The following is a description of a gene set: Constipation for longer than three months with fewer than 3 bowel movements per week, straining, lumpy or hard stools, and a sensation of anorectal obstruction or incomplete defecation. studied in species Homo sapiens Chronic constipation Human Gene Set: HP_CHRONIC_CONSTIPATION, and this is the list of marker genes: SLC38A3, PWRN1, LMNB1, CREBBP, H4C5, TRIM8, ELN, MYH11, BICRA, MYO1H, FBXO28, DDOST, MLXIPL, ASH1L, EHMT1, IPO8, CAMK2B, COL1A1, DNAJC13, B2M, PHOX2B, ODC1, EP300, ADNP (NCBI Gene Id 256440), SMO, SH2B1, UBE2A, HERC2, TFE3, SNORD115-1, SETD5, PWAR1, SLC25A36, SNORD116-1, SNCA, ELF4, H3-3A, MLYCD, LMNB2, WASF1, KMT5B, GRIA1, GBA1, RAI1, EIF5A, PCGF2, DCPS, COL5A2, GNB2, SLC32A1, MSL3, UPF3B, TNFRSF1A, TBCD, HNRNPH2, AFG2A, LBX1, FGF12, MKRN3, VPS35, COL5A1, POGZ, SUPT16H, H1-4, SLC12A2, PPP2R1A, USP7, PSMB8, GIGYF2, NPAP1, CNP, OPA1 (NCBI Gene Id 4976), TMCO1, H3-3B, MEFV, OTUD6B, NGLY1, UGP2, USP9X, PLCB4, MOGS, FAR1 (fatty acyl-CoA reductase 1), RORA (NCBI Gene Id 6095), ARSB, AFF3, SOX17, TANC2, ABL1, SETD1A, EIF4G1, TCEAL1, PRKG2, POU4F1, MNX1, PPP1CB, ERBB2, MECP2, PPP1R21, GATAD2B, TRIO, UFC1, NAA80, SPART, CTCF, SEC61A1, ZNF292, MADD, ADAT3, MED13, CAMTA1, NSD2, HS2ST1, LRRK2, MAGEL2, IGBP1, PAK2 (NCBI Gene Id 9106), HIVEP2, MARS2, TAOK1, SPOP